The following is a description of a gene set: Any process that modulates the frequency, rate or extent of wound healing, spreading of epidermal cells. Mouse Gene Set: GOBP_REGULATION_OF_WOUND_HEALING_SPREADING_OF_EPIDERMAL_CELLS species: Mus musculus, and this is the list of marker genes: Fermt2, Pten (NCBI Gene Id 70161), Clasp2, Mtor, Fermt1, Clasp1, Phldb2, Rreb1